Given this list of marker genes ZMYND11, HPRT1, BYSL, CRIP1, BHLHE40, SAT1, IL27RA, MAD2L1, ASNS, SLC7A5, SNRPF, UCHL1, UBE2S, GSAP, RIPOR2, ZBTB20, SLC46A3, PSMD1, PSMD14, QPCT, SRSF1, CTSH, SSRP1, POLD2, BIN1, TPX2, TUBG1, FEN1, AFG3L2, MAP1B (microtubule associated protein 1B), IFITM1, NOP16, HSPA9, SRGN, CTNNA1, WDR18, SLC25A4, AHNAK, SLC39A14, ITM2A, CASP4, SECISBP2L, LORICRIN, XPOT, CYCS, FAM98A, PSMA3, AHSA1, OGA, EEF1E1, ITPR1 (inositol 1,4,5-trisphosphate receptor type 1), PLCB2, NME1, HHEX, PRDX4, MRPS12, EIF4G1, LSM3, HLA-E, PES1 (pescadillo ribosomal biogenesis factor 1), ZYX, PRDX3, SAR1A, LGALS9, DBF4, TGOLN2, ETHE1, FCMR, SLC4A3, ARVCF, DESI1, SUN2, ITPR2, GARS1, MVP, LAPTM5, TOMM40, PSMB2, POLR2F, EMG1, N4BP2L2, SP100, PRKCB, BLMH, USP4, CD44, CSE1L, SERBP1, BUD31, PSMB5, CCNB1, CCNA2 (NCBI Gene Id 890), RPS26, SSBP1, CCND2, SPG11, ANXA6, LGALS1, NDUFAB1, ELOC, TCP1, N4BP2L1, EIF2S1, HDDC2, MRPL3, EBNA1BP2, RBM5, MYL12A, CTPS1, S100A4, PCNA, RCC1, HCP5, P2RY10, HSPE1 (heat shock protein family E (Hsp10) member 1), PAICS, TRIP13, ORC5, HNRNPAB, PSMB7, TIMM17A, TEP1, PRSS53, RUVBL2 (RuvB like AAA ATPase 2), DDB2, UCK2, ZNF593, CYLD, H2AC18, CDK1, CYC1, NISCH, PSMD2, GABARAP, SEM1 (NCBI Gene Id 7979), AIMP2, LITAF, POLR2H (RNA polymerase II, I and III subunit H), RFC4, TNFRSF1B, EPOR, MDFIC, TPP1, MRPL12, NDRG1, here is a description of the gene set: Cellular phenotypes are determined by the differential activity of networks linking coregulated genes. Available methods for the reverse engineering of such networks from genome-wide expression profiles have been successful only in the analysis of lower eukaryotes with simple genomes. Using a new method called ARACNe (algorithm for the reconstruction of accurate cellular networks), we report the reconstruction of regulatory networks from expression profiles of human B cells. The results are suggestive a hierarchical, scale-free network, where a few highly interconnected genes (hubs) account for most of the interactions. Validation of the network against available data led to the identification of MYC as a major hub, which controls a network comprising known target genes as well as new ones, which were biochemically validated. The newly identified MYC targets include some major hubs. This approach can be generally useful for the analysis of normal and pathologic networks in mammalian cells. species: Homo sapiens from publication Basso K, Margolin AA, Stolovitzky G, Klein U, Dalla-Favera R, Califano A (PMID 15778709) Genes which comprise the top 1% of highly interconnected genes (major hubs) that account for most of gene interactions in the reconstructed regulatory networks from expression profiles in B lymphocytes. Human Gene Set: BASSO_B_LYMPHOCYTE_NETWORK